The following is a description of a gene set: Abnormality of the elbow Human Gene Set: HP_ABNORMALITY_OF_THE_ELBOW An anomaly of the joint that connects the upper and the lower arm. studied in species Homo sapiens, and this is the list of marker genes: SMOC1, GPC6, PLOD2, CDC45, PRKAR1A, ORC6, OBSL1, SLC25A46, COL6A1, IFITM5, PEX1, RNU4ATAC, COL5A2 (collagen type V alpha 2 chain), PPP2R3C, SRY, DONSON, ESCO2, NIPBL, NF1, ENPP1, LARGE1, GLDN, SYNE2, RECQL4, HOXA11, WDR11, FGF9, CAPN3, CDT1, ERCC6, TDO2, LRP4, RSPO2, PIGY (phosphatidylinositol glycan anchor biosynthesis class Y), CCN6, BANF1, HSPG2, ATP7A, MYH3, SALL4, HS2ST1, MED12, CPT2, SCARF2, KDM5C, SIL1, ERGIC1, KCNK9, EVC2, COL6A2, FBXO11, TFE3, ASPH, ANO5, TPM3, HACD1, B3GAT3, GMNN, B3GLCT, FGFR2, SKI, MYL11, MYOT, ALDH18A1, SMC1A (NCBI Gene Id 8243), APC, MET, ITGA7, DYNC2LI1 (NCBI Gene Id 51626), SNRPB, PLOD1, PSTPIP1, CD96, LTBP3, ATR, P4HTM, UNC80, RMRP, COLEC10, POP1, COL12A1, COMP, TOR1A, BRD4, DMD, GNB2, CYP26B1, GJB2, FGFR1 (fibroblast growth factor receptor 1), GHR, KIF22, RAB33B, PTH1R, GLI1, COL6A3, ASXL1, LGI4, ERI1, CSGALNACT1, SOX9, ROR2, AEBP1, GSC, PYCR1, SOS1, CDC6, STAG1, POR, DYSF, COL1A1, FHL1, DDR2, KMT2A, GNPNAT1, MUSK, EMD, CLCN3 (chloride voltage-gated channel 3), FBXO28, NPR2, WNT7A, RSPRY1 (ring finger and SPRY domain containing 1), SLC26A2, DYM, MAP2K1, ERLIN2, IDH1, MAFB, HEATR3, PSMB8, CRLF1, PRG4, LAMA2, PLOD3 (NCBI Gene Id 8985), SRCAP, PTDSS1, COL2A1, ORC1, FILIP1, HNRNPH1, WNT4, COLEC11, GDF5, MACROH2A1, DVL3, SLC29A3, NALCN, GNS, NXN, ASAH1 (NCBI Gene Id 79795), TUBB3, UBA1 (ubiquitin like modifier activating enzyme 1), MATN3, BMP1, FZD2, CYP27A1, EZH2, GRB10, FLNA, ERCC1, SCYL2, SLC6A9, ITCH, IDH2, EXTL3, PRMT7, ARID1B, GALNS, FLNB, B3GALT6, COL9A3, FGFR3, MAPK1, PTPN11, PEX5, TRPV4, SFRP4, MECOM, VPS13B, HDAC8, SLC39A13, B4GALT7 (NCBI Gene Id 202179), CANT1, BPTF, ECEL1, PRKACB, FKBP10, CCDC8, MYL1, NUP107, STXBP1, TAF6, COL7A1, TPM2, GNB1, PITX1, PPP1CB, SLC39A8, IDUA, HEPHL1, MMP13 (NCBI Gene Id 4322), LARS2, WNT5A, CUL4B, CREBBP, RAD21, ORC4, BCOR, FBN1, PRKACA, COL27A1, COL25A1, SMC3, CHRNG, SPRTN, KRAS (NCBI Gene Id 3845), CBL, XYLT1, BRAF, TMEM222, COL9A2, TONSL, GJA1 (NCBI Gene Id 7953), PEX2, NOG, BPNT2, SHOC2, SPRED2 (NCBI Gene Id 200734), SVIL, TRAPPC2 (NCBI Gene Id 6399), AFF3, ABCC6, CLCF1, LMX1B, PCNT, LBR, GLE1, MASP1, TBX15 (NCBI Gene Id 6913), NOTCH2, ACTA1, HRAS, COL9A1, EXOC6B, DVL1, CHST3, L1CAM, TMEM43, LMNA, TFAP2A, IL6ST, MAP3K20, EVC, SHOX, PIK3C2A, MYL2, BGN, KY, LZTR1, FDFT1, FBN2, SYNE1, ABCC9, SELENON, SF3B4, COL5A1, PSMD12, SCN4A, TBX3, JAG2, TBX5, MAP3K7, CUL7, OPA3, LMBRD2, SLC35B2, SMAD6, RAF1, MAP2K2, EP300, TAF4, SYT2, LIFR, PIGA